The following is a description of a gene set: studied in species Homo sapiens Human Gene Set: WP_GENES_RELATED_TO_PRIMARY_CILIUM_DEVELOPMENT_BASED_ON_CRISPR Genes related to primary cilium development (based on CRISPR), and this is the list of marker genes: BBS12, IFT140, IFT80, MIB1, RAB23, SASS6, TMEM67, CIBAR1, KIF3B, EFCAB7, BBS7, CPLANE1, IFT74, KIAA0753, IFT122, ARL3, CEP20, CEP192, CPLANE2, CEP162, IFT27, IFT57, CEP43, CEP44, RABL2A, ARMC9, KIF3A, MKKS, TMEM107, CEP120, IFT20, IFT81, TMEM216, RPGRIP1L, LZTFL1, FBF1, TTC21B, CEP104 (NCBI Gene Id 9731), EVC, ARL13B, PIBF1, TXNDC15, WDPCP, CEP97, TMEM17, CEP83, TCTN2, CILK1, BBS9, DYNC2I2, DYNLL1, TEDC1, BBS5, TULP3, BBS1, IFT56, TUBE1, ARL6, TTBK2, CDK20, TTC8, CEP76, IFT46, CC2D2A, MKS1, OFD1, CBY1, DYNLT1 (NCBI Gene Id 6993), DYNC2I1, IFT25, TTC23, WDR19, TMEM231, TCTN1, FUZ, B9D1, TRAPPC11, BBS2, TRAF3IP1, KATNB1, IFT52, BBS4, C2CD3, TEDC2, KIFAP3, CEP295, CEP19, INPP5E, IQCE, WDR35, SCLT1, IFT70B, EVC2, DYNC2H1, TUBD1, DYNLT2B, BBS10, TCTN3, IFT88, IFT43, DYNC2LI1, IFT172, CLUAP1